Given this list of marker genes Dcn, F3, Rag1, Actb, Mir23a, Apob, Pms2, Tead3, Vim, Rbbp7, Adgrb3, Abcb1a, Wt1, Jak1, Hnrnpk, Hamp2, Rab7b, Stk11, Rnf157, Scube3, Lpar1, Dcstamp, Gdpd2, Plcg1, Csf3, Rhoh, Hsp90aa1, Fgfr2, Lrp2, Numa1, Adgrl3, Tiam1, Mir100, Igf2, Scube2, Cux2, Pak1, Foxg1, Amtn (NCBI Gene Id 71421), Zfp703, Xbp1 (NCBI Gene Id 52219), Crp, Glipr2, Trpv2, Slitrk6, Fam210b, Mkks, Cela1, Hmgcr, Six4, Dag1, Numb, Sox8, Ehd1 (NCBI Gene Id 13660), Lrrn1, Dlg5, Iqsec2, Picalm, Ifitm1, Srf, Nkx6-2, Caprin1, Neurl1a, Pik3r1, Ifi204, Bmpr1b, Pkdcc, Atp11c, Notch2, Zbtb46, Tespa1, Gab1, Il1rapl1, Mief2, Tgfb3, Cd101, Cyb5d2, Cobl, Smyd1, Trp63, Id2, Amigo3, Zfp335, Ccn1, Bdnf, Zbed3, Clu, Ccr7, Il33, Aspa, Nap1l2, Hnrnpu, Lgals9, Hif1an, Ppp1r13l, Tnfsf13b, Nfkbid (nuclear factor of kappa light polypeptide gene enhancer in B cells inhibitor, delta), Sdcbp, Dll1, Musk, Crebbp (NCBI Gene Id 547230), Cited2, Wnt7b, Sox17, Wwtr1, Llph, Jund, Metrnl, Chd7, Foxs1, Fgfr1, Nefl, Ccn5, Mtdh, Cyp51, Kat2a, Nras, Rcor1, Lamb1, Suco, Bmpr1a, Hoxc11, Hax1, Adamts20, Jun, Adgrl1, Fxn, Duoxa1, Cbln2, Ptprf, Car2, Eif2b2, Wdr62, Shox2, Ddr2, Dusp10, Ehd2, Arid4a, Myf6, Cma1, Btc, Itsn1, Skil, Arx, Prl, Il3, Tgfbr1, Fermt2, Abl1, Slitrk1, Smoc2, Bcl6, Cpne5, Axin2, D16Ertd472e, Hamp, Xrcc2, Sgk1, Tent5a, Ncam1, Prkch, Gdpd5, Ntrk3, Smarcc2, Pdlim7, Col1a1, Pithd1, Flrt3, Ascl1, Exosc3, Bmp7, Sry, Vldlr, Lmod3, Rnd2, Shtn1, Eif4g1, Pxn, F11r, Ell3, Dkk1, Hspa1b, Prmt5, Nsd2, Slc25a4, Tcf15, Zfhx3, Spdef, Prl4a1, Ss18, Nkx6-1, Il18, Prl2c2, Znhit1, Ccn2, Smarce1, Cpne9, Adig, Grem1, Atoh1, Emilin2, Bex1, Cyfip1, Dpf3, Cebpa, Cdkl5, Hyal1, Hmgb1, Insm1, Iqgap3, Ghrhr, Snw1, Scx, Mir34a, Gpr68, Efna5, Etv2, Shld2, Bmpr2, Caprin2, Sinhcaf, Sgip1, Akap11, Slc39a12, Dvl2, Traf6, Tmprss12, Zmynd8, Jcad (junctional cadherin 5 associated, NCBI Gene Id 68804), Wnk1, Hmg20b, Lyn, Pbrm1, Bcl2, Adam8, Tnfrsf13c, Dab1, Flrt2, Gcnt2, Maml1, Stat3, Egf, Ada, Dixdc1, Clstn3, Arrb2, Etv5, Lrtm1, Fgf1, Sult1e1, Ephb3, Wnt10b, Star, Hipk2, Klhl25, Mtor, Il4i1, Nipbl, Ctnnb1, Bcl11a, Ovol2, Hap1, Tert, Mir23b, Ranbp3l, Mamstr, Setd3, Dkkl1, Ifng, Adam9, Msx2, Shoc2, Neurod4, Prkaa1, Kmt5c, Arid1a, Serpine1, Lif, Atp8a2, Ngf, Smad4, Myod1, Ddhd2, Stox1, Ipo7, Gsk3b, Smap1, Inpp5d (inositol polyphosphate-5-phosphatase D), Ccl19, Wnt5a, Ednra, Esrrb, Casp6, Rif1, Agr2, Cd1d1, Dio3, Slit2, Hsp90ab1, Cdc20, Twist1, Rac1, Tnfsf14, Ccl9, Fbn2, Anxa3, Hsf1, Slitrk5, Il6st, Dact1, Stat5a, Rps6kb1, Usp2, Gli3, Ltf, Il10, Pak4, Gata3, Lpl, Erap1, Trpc5, Tnfsf9, Ctsh, Fzd4, Lmna, Tead4, Tcf3, Shank1, Qki, Amigo2, Adgre5, Golga2, Mir103-2, Tal1, Brd2, Ccl24, Kras, Ephb1, Yme1l1, Clip1, Mmd, Stk4, Fgfr4, Ihh, Phox2b, Hoxb4, Arhgef2, Cdkl3, Mmp9, Ybx3, Socs3, Ctf2, Mir24-2, Cd40lg, Tfrc, Osr1, Sema5a, Macroh2a1, Acvrl1, Nkap, Atp11a, Alox8, Zfp36, Khdc3, Ankrd27, Aamdc, Ufl1, Mecp2, Robo2, Cd74, Prl3a1, Ninj1, Junb, Foxo3, Foxn1 (NCBI Gene Id 51955), Mir675, Gper1, Ephb4, Lig4 (ligase IV, DNA, ATP-dependent), Nr5a1, Fzd3, Kdf1 (NCBI Gene Id 69073), Dlx2, Lpar3, Gata6, Rapgef3, Pml, Pcp4, Il4ra, Hspa5, Fzd9, Mydgf, Cyp1b1, Cd28, Smo, Mapk8, Rb1, Ccne1, Cxcl12 (NCBI Gene Id 20315), Sirt1, Pld6, Parp1, Ilk, Nkx2-2os, Mir143, Stk25, Hoxa5, Irf1, Mir3960, Prl7a1, Itpkb (NCBI Gene Id 68660), Itgax, Brd9, Maged1, Il15ra, Prkcb, Six1, Crtc1 (CREB regulated transcription coactivator 1), Smad9, Ago2, Por, Skint1, Bag1, Smarca2, Fn1, Tbx21, Serp1, Rara, Mapk6, Dbn1, Pdgfra, Foxa1, Thpo, Elapor2, Eng, Acin1, Brinp2, Dlk1, Smad5, Camk2b, Parp2, Spry1, Ccnd1, Sphk1, Aspm, Akirin1, Neurod1, Anapc2, Mapk14, Dnm1l, Prkg2, Prkdc, Tyrobp, Clic1, Islr2, Pin1, Nlrp4f, Lcn2, Aplnr, Nfatc2, Clic3, Nlrp5 (NCBI Gene Id 23968), Tox, Lingo2, Cdkn2a, Acacb, Id4 (NCBI Gene Id 15904), Il1a, Hoxd11, Iqsec1, Pdpk1, Ppard, Serpinf1, Prkci, Tie1, Ankrd54 (NCBI Gene Id 27619), Tradd, Zp3, Arhgap32, Sfrp1, Faim, Pdpn, Cd46, Sox2, Ctnnbip1, Sirt6, Flna, Fmr1 (NCBI Gene Id 207836), Gpr21, Cask, Ddhd1, Zfp385a, Il12b, Celf1, Il2rg (NCBI Gene Id 16186), Prl3c1, Isl1, Wnt3, Cysltr2, Clstn2, Lck, Nudt21, B4galt5, Rasal1, Erbb4, C3, Jade2 (NCBI Gene Id 76901), Zfp219, Atraid, Mustn1, Kdr, Jup, Ube2v2, Pde5a, Fbxo5, Dmrt1, Ager (NCBI Gene Id 11596), Gh, Prl2c1, Aurka, Ptpra, Plcb1, Loxl2, Adrb2, Stat1, Bnip2, Edn1, Slitrk3, Gimap3 (NCBI Gene Id 83408), Atf4, Mcub, Ogt, Pou1f1, Il34 (interleukin 34), Mst1, Iqgap1, Ptger4, Alox12, Igtp, Itgb2, Rxrb, Nek5, Atp2b1, Adam7, Prl8a1, Spi1, Evi2b, Capn3, Hoxd3, Flot1, Foxc1, Ptch1, Tbc1d24, Itgb8, Vash2, Bad, Pax4, Hif1a, Dvl3, Ndel1, Bin1, Cdon, Crabp2, Prl3d2, Pde3a, Hdac1 (NCBI Gene Id 630524), Axl, Prox1, Stk3, Mir137 (NCBI Gene Id 387155), Lrrc4b, Adnp, Foxj1, Dpf2, Erbb3, S100a1, Ntrk1, Rras, Ephb2, Ramp2 (NCBI Gene Id 54649, receptor (calcitonin) activity modifying protein 2), Itsn2, Fgf10 (fibroblast growth factor 10), Cul7, Akt1, Adrb1, Pten, Jag1, Mapt, Klf10, Agtr1a, Apc, Smurf2, Ptn, Clstn1, Il4, Tmem64, Smarcd3, Sirt2 (NCBI Gene Id 80489), Nr1h4, Hc, Pnp, Map2k2, Vsir, Gata5, Dlg1, Lgals3, Dab2, Zap70, Cth, Megf8, Gli2, Kdm2b, Rhoa, Dbnl, Cdk1, Sox13, Lrrtm4, Sfn, Nfkbiz, Foxc2, Srrt, Msh2, Synj1, Sp7, Tcf7l2, Rhob, Nog, Ikzf1, Rela, Sema4a, Prl7c1, Tgfbr2, Gli1, Nodal, Fkbp1b, Csf2, Macroh2a2, Sash1, Spire1, Pak3, Zbtb16, Lbx2, Lrp5, Rtn4, Sox6, Agtr1b, Prl8a8, Angpt2, Syndig1, Ltbp3 (NCBI Gene Id 16998), Mir210, Tnfrsf1b (NCBI Gene Id 21938), Csf1, Slc8a1, Xrcc5, Bcl7c, Rin2, Adgrb2, Prl2b1, Notch1, Mir326, Nap1l1, Camk1, Cd27, Cip2a, Smurf1, Sin3a, Epha4, Amot, Hoxb7, Dlx1, Commd5, C1qbp, Mup20, Il23a, Tcf12, Limk1, Serpinf2, L1cam, Agap2, Fut1, Bbs2, Prkca, Gata1, H2-M3, Mir219a-2, Camp, Vnn1, Efemp2, Agtr2, Fst, Amigo1, Il2 (NCBI Gene Id 16183), Bmp2, Kat5, Rpl4, Rbpj, Hey2, Akap5, Rgs14, Lrrtm2, Ptprc, Pik3r6, Map1b, Pax6 (NCBI Gene Id 18508), Adcy10, Trpc6, Tshz3, Add1, Trib1, Acvr2a, Ccn6, Efnb2, Socs1, Plxnb2, Cftr, Prdm14, Mir24-1, Pou4f2, Exosc6, Prpf19, Emilin1, Pin1rt1, Shh, Pdcd6, Sult2b1, Brca1, Mixl1, Clasp1, Adgrl2, Nr5a2, Inhba, Bax, Prl3b1, Bmal1, Aqp1 (NCBI Gene Id 11826), Itgb2l, Smarcd2, Mir27b, H2-Ea, Cfl1, Metrn, Sox11, Tbx1, Ghrl, Pias1 (protein inhibitor of activated STAT 1), Plxnb1 (plexin B1), Psg22, Otp (NCBI Gene Id 18420), Pafah1b1, App, Ripk2, Gnas, Zc3h12a (NCBI Gene Id 230738, zinc finger CCCH type containing 12A), Phldb1, Ahi1, Vegfb, Cdh5, Pa2g4, Bmp10, Odaph, Prl3d3, Prl8a9, Vstm5, Egfr, Mff, Kmt5b, Kat8, Ccl3, Aggf1, Brd4, Dscam, Atad5 (NCBI Gene Id 319895), Kdm5b, Zdhhc6, Fgf18, Zhx3, Smarcc1, Nckap1l, Bcl9l (B cell CLL/lymphoma 9-like), Sp1, Neurog2, Trp73, Rala, Actr3, Zfp322a, Mir103-1, Mag, Tmem79, Adipoq (NCBI Gene Id 11450), Tlr2, Pla2g5, Dnai3, Coro1c, Carm1, Timp2, Smarcb1, Srpx2, Tnfrsf11a, Elavl4, Ep300, Jmjd8, Alk, Cbln1, Hoxa11, Faxdc2 (fatty acid hydroxylase domain containing 2), Ncoa2, Ambra1, Nlgn3, Krt17, Map3k13, Tek, Ccr3, Cysltr1, Tcf4, Brms1l, Gdnf, Il1rl2, Stat5b, Gfi1b, Bmp4, Cyld, Lingo4, Met, Pcid2, Arid2, Carmil2 (capping protein regulator and myosin 1 linker 2), Bhlhb9, Gas6, Dmbt1, Lrg1, Tph1 (tryptophan hydroxylase 1), Wnt2b, Xrcc4, Eif5a, Itpka, Slc30a1, Foxo6, Ppib, Zc4h2, Pum2, Rheb, Prl7d1 (prolactin family 7, subfamily d, member 1), Myb, Ntn1, Ppargc1b (peroxisome proliferative activated receptor, gamma, coactivator 1 beta), Kl, Nfe2l2, Igfbp3, Socs5, Cpeb3, Tgfbr3, Thbs1, Trip10, Irgm1, Hdac2, Slc9b2, Casp8, Gal, Dubr, Xrcc6, Nedd4l, Ddah1, Cyp26b1, Prl2c5, Spint1, P2rx7, Stk24, Brd1, Pgf, Ache, C5ar1, Evi2, Il2ra, Bnip3, Igf1, Pls1, Actr2, Ccr1, Mfn2, Gprc5b, Slc23a2, Tacstd2, Cux1, Ccl5, Irx3, Krt10 (keratin 10), Il12a, Ccr5, Fadd, Pck1, Foxa2, Sfrp2, Sart1, Foxd1, Proc, Wnt7a, Scgb3a1, Nkx2-5, Tgfb1i1 (NCBI Gene Id 21804), Kctd11, Prl7b1, Tshr, Etv4, S1pr2 (NCBI Gene Id 68430), Eeig1, Boc, Hopx, Tnfsf4, Drd2 (dopamine receptor D2), Zeb2, Notch4, Tspo, Lrrtm3, Lama2, Lilrb4b, Nrxn1 (NCBI Gene Id 68042), Syt17, Foxa3 (forkhead box A3), Tnn, Pdgfb (platelet derived growth factor, B polypeptide), Disc1, Crebl2, Tnfrsf12a, Mad2l2, Tbx20, H2-Aa, Wnt4, Alx1, Fxr2, Bmp1, Tgif1 (TGFB-induced factor homeobox 1), Pex5, Ppp1cc, Dct, Capn2, Trak1, Bloc1s6, Prmt1, Vdr, Tbx2, Htr2c, Nlgn2, Epha1, Pink1, Ptprz1, Gata4, Akt3, Pgam5, Retn, Cthrc1, Tgfb2, Egr2 (early growth response 2), Chodl, Nedd9, Acvr1, Bnc1, Unc5c, Glul, Sec1, Otx2, Ngfr, Xkr8, Paxip1, Mir223 (NCBI Gene Id 723814), Obsl1, Npnt, Fes, Prkn, Mief1, Opa1, Mir214, Slc6a6, Adm2, Golga4, Syt3, Isg15 (NCBI Gene Id 53606), Prl8a6, Mapk8ip3, Rbm19, Sema4d, E2f1, Tlr9, Fzd1 (NCBI Gene Id 14362), Ntf3, Mapk1, Dmrt2, Sorl1, Macf1, Slc4a2, Gjc2, Gdi1, Oxt (oxytocin), Rassf10, Smarca4, Itgam, Gja1, Ptk2, Il36b, Lrrtm1, Brinp3, Csrp3, Hes1, Lrrc24, Mme, Sox10, Ace, Adm, Mturn, Sema7a (NCBI Gene Id 78407), Tle6, Il1b, Ano6, Msr1, Bmper, H2-DMa, Klf5, Glp1r, Grn, Grip1, Zbtb7c, Ghr, Abcb10, Dlx5, Ccl8, Yap1, Nptn, Phf10, Scin, Psen1, Lbh, Cd4, Wars2, Nlgn1, Irgm2, Men1, Hmces, Fdps, Ror2, Dnmt3b, Mtm1, Prl7a2, Cdh4, Fgf9, Vwc2l, Wnt9a, Olfm1, Asb4, Cyp27b1, Asic2, Clasp2, Wnt2, Clcf1, Kit, Scarf1, Suds3, Neurog1, Vegfa, Dlg4, Map3k5, Ptk2b, Il7r (NCBI Gene Id 223338), Socs2, Vil1, Parp6, Syt4, Shld3, Bend6, Nrg1, Ocstamp, Osr2, Gfap, Acvr2b, Zbtb7b, Mmrn2, Flrt1, Dicer1, Mia3, Adamts9, Fndc5, Lilrb4a, Plxnd1, Tlr3, Cldn5, Cdx2, Sptbn4, Rag2, Tet1, Gdf3 (NCBI Gene Id 97289), Pias2, Lamb2, Tmsb4x, Nlrp3 (NCBI Gene Id 216799), Il21, Cebpd, Il20, Akap6, Tmem119, Ccbe1, Mrtfb (NCBI Gene Id 239719), Ccn4, Tjp1, Eif4g2, Nrp1, Myc, Lep, Zfp488, Egr3, Fis1, Rack1, Tarbp2, Gfi1, Arid4b, Adgrv1, Prdm16, Hlx, Uts2r, Cebpb (NCBI Gene Id 18031), Edn3, Sh3gl3, Tgfb1, Rab21, Ezh2, Kitl, Sh3pxd2b, Angptl3, Ffar4, Pou3f2, Gdf6, Wnt5b, Ccnd2, Tnfsf11, Crxos, Kdm1a, Sox15, Pla2g3, Plaa, Igf1r, Lrrn3, Alox5, Atxn1, Ss18l1, Zbtb1, Oprm1, Twf2, Anxa1, Hcls1 (hematopoietic cell specific Lyn substrate 1), Morf4l2, Rarres2, Bcl7a, Gpam, Dmrta2, Smad2, Fgf3, Smad7, Adgrb1, Tescl, Ncoa1, Sod2, Lef1, Fbxw8, Heyl, Brinp1, Olfm2, Snai1, Smad3, Ccdc3, Myocd, Grm5, Rims1, Slc7a5, Hey1, Gimap5, Kdm4c, Cbfb, Ccn3, Prl2a1, Myrf, Sfrp4, Noct, Rims2, Wls, Mir875, Tbx5, Mul1, Bbs4, Smarcd1, Malt1, Zfp609, Cdkn2b, Ccl11, Frzb, Eef2k, Oxtr, Tnf, Mecom, Chi3l1, Pparg (NCBI Gene Id 19016), Actn3, Ddx39b (DEAD box helicase 39b), Lrp3, Rgcc, Tapt1, Pwp1, Map6, Napepld, Kdm4a, Rbbp4, Fos, Angpt4, Vps35, Sash3, Nfkb1, Cds1, Vegfc, Tgif2, Lhx1, Spen, Mir27a, Pacsin1, Baiap2, Dab2ip (disabled 2 interacting protein), Hgf, Fam20c, Mtch2, Cd34, Unc13a, Dvl1, Lin28a, Prl6a1, Ncoa3, Klf4, Hdac6, Gcm1, Itgb1, Lta, Lrp8, Trpm4, Mir124a-3, Tesc, Il7, Mir124a-2, Zfpm2, Hmga2, Tbxa2r (NCBI Gene Id 21390), Acvr1b, Ceacam1, Brms1, Flt3l, Csf1r, Cxcr4, Brd7, Ets1, Snai2, Apela, Clcn2, Vwc2 (NCBI Gene Id 319922), Cmklr1, Runx3, Bloc1s5, Tbx18, Sap30, Ezr, Ppp1r9a, Dhx36, Ppp3ca, Tsc2, Nr3c1, Prl8a2, Ptgis, Gpm6b, Stau2, Snap91, Dcx, Nr6a1, Ist1, Cybb, Fgfr3, Syap1, Insr, Ralbp1, Ripor2, Rasgrp1, Arf1, Pax8, Hmox1, Gsx2 (GS homeobox 2), Utp25, Fgf2, Cpne1, Dpf1, Shb, Nell1, Pkm, Cd83, Uchl3, Slitrk2, Il6, Itga5, Mmp14, Nf2, Kat7, Src, Adgrl4, Dspp, Lrtm2, Lgr4, Zmiz1, Pagr1a, Plxnc1, Plag1, S100b, Mlh1, Hpse, Slc6a3, Cpne6, Ccnb1, Ccr1l1, Creb1, Pth, Lrp1, Mdk, Cxcl9, Neu2, Fezf1, Shank3, Rgs6, Man2a1, Zdhhc15, Fgf8, Serpine2, Mylk3 (myosin light chain kinase 3), Ar, Myog, Sox4, Cxcr3, Prl5a1, Trim32, Syk, Fbxo31, Thbs2, Ptch2, Sh3glb1, Rufy3, Sall1, Ssbp3, Mapk9, Cd24a, Sema3a (sema domain, immunoglobulin domain (Ig), short basic domain, secreted, (semaphorin) 3A), Neurod2, Nppc, Msx1, Dll3, Cav3, Kalrn, Atoh8, Crb2, Mef2c, Reg1, Sox5 (SRY (sex determining region Y)-box 5), Trf, Thrb, Enam, Tnik, Stim1, Btg1, Ect2, Nkx2-2, Sox9, Uts2, Nin, Tfe3, Cxcr2, Pkp1, Epo, Gdf2, Frs2, Trem2, Sav1, Ptgs2, Btn2a2, Wnt1, Rxra, Grip2, Neurog3, Nmnat1, Xlr3b, Slitrk4 (NCBI Gene Id 245446), Runx2, Gata2, Dmd, Cacna2d2, Tnfsf13, Cx3cl1, Pik3cd, Slc20a2, Rptor, Marchf5, Tiam2, Cd40, Mdm2, Tmem100, Nr2c2, Clec7a, Mmd2, Pou4f1, Shld1, Ecm1, Cd36, Ddrgk1, Syde1, Sap30l, Rnf112, Ccr2, Mfn1, Ghrh, Vezf1, Mpl, Pim1, Prkd1, Il5, Marcks, Prl3d1, Bambi, Phldb2 (NCBI Gene Id 547265), Tgm2, Zfp365, Bicra, Apoe, Runx1, Mcu, Nbl1, Mesp1, Ret, Tnfrsf1a, Bcl7b, Ing2, Lamc1, Nr2e1, Hspb6, Lrrc8a, Itgb3, Cd53 (CD53 antigen), Tfap2a, Coro1b, St8sia2, Cntf, Mir219a-1, Reln, Adra2b, Hspb1, Nos3, Rfx3, Upf3b, Numbl, Foxp3, Impact, Dsg2, Plxnb3, Bmp5 (NCBI Gene Id 12160), Syt1, Emp2, Olig2, Nrdc, Agrn, Gdf5, Rreb1, Rbm24, Rbm4, Ghsr, Tpbg, Stat6, Pdcl3, Agt, Jak2, Lama1, Ripk1, Il1rap, Trp53bp1, Rapgef2, Grid2, Ppp2r3c (NCBI Gene Id 80481), Tmem106b, Epc1, Nid1, C3ar1, Gdf10, Adam12, Prkd2, Il15, Prmt3, Medag, Syce3, Il17a, Ap3b1, Nme2, Eif2s3y, Piezo1, Afdn, Zeb1, Myo5b, Fezf2, Mapkapk5, Robo1, Ap3d1, Syt2, Flt1, Enpp2, Spag9, Wnt3a, Fxr1, Palm, Pax2, Tenm4, Cd276, Ptprd, Lmo3, Emc10, Prom1, Htr2a, Hk2, Zfyve27, Fndc3b, Gdf15, Actl6a, Krt2, Cx3cr1, Myf5, Smad1, Asxl2, Adra2c, Med1, Zfp36l1, Wdfy2, Gpc1, Sox12, Flt3, Prl2c3, Actl6b, Ing1, Map2k1, Vstm2a, Tead1, Rap1a, Ntrk2, Sap130, Nfatc3, Mir124a-1, Hmgb2, Dhx37, Cacng7, Gdf7, Wnt6, Bmp6, Braf, Prkcz, Bicral (NCBI Gene Id 210982), Rest, Wif1, here is a description of the gene set: Any process that activates or increases the rate or extent of development, the biological process whose specific outcome is the progression of an organism over time from an initial condition (e.g. a zygote, or a young adult) to a later condition (e.g. a multicellular animal or an aged adult). Mouse Gene Set: GOBP_POSITIVE_REGULATION_OF_DEVELOPMENTAL_PROCESS studied in species Mus musculus